Given this list of marker genes Spesp1, Pabir2, Pou2af2 (NCBI Gene Id 69809), Magi3, Or10ad1c, Fryl, Nrk, Ugt8a, Zmat2, Med1, Aqp6, Spock1, Plxnb3, Bcl11a, Stc2, Galnt7, Lman1, Atg14, Nsd1, Strbp, Csnk1d, Erfe, Tmtc4, Sh3rf1, Amph, Lrrn4cl, Casp2, Zfp24, Cacnb2, Fndc4, Rbm24, Evc, Glul, Chmp1b2, Mbd2, Rtn3, Cog5, Astn1, Usp3, Tpm1, Tshz1, Bend6, Ube2d3, Tox3, Foxf1, Hmcn1, Scn8a, Adgrd1, Abhd17b, 2410004B18Rik, Rmnd5b, Slc12a6, Armcx6, Trappc8, Plk2, Fam184a, Btaf1, Rpf1, Kcnd2, Babam1, Nfasc, Myo1e, Fbln2, Snap91, Atf7ip, Stac2, Rimbp2, Pigm, Nek6, Ppp4r2, Pcdhb10, Hycc2, Isca2, Cdh20, Nubp1, Mycbp2, Mylk, Nme7, Fry, Nfx1, Plxnc1, Epb41l3, Atp6v1c1, Ilk, Saxo2, Lztfl1, Bmal2, Phf20l1, Rab11fip1, Fbn1, Dpysl2, Mtcl2, Ube2i, Rarb, Hip1, Tacc1, Trdmt1 (tRNA aspartic acid methyltransferase 1), Prpf38b, Serpina3f, Col25a1, Zdhhc3, F11, here is a description of the gene set: from publication Chen Y, Wang X (PMID 31504780) species: Mus musculus Mouse Gene Set: MIR_216A_3P Genes predicted to be targets of miRBase v22 microRNA mmu_miR_216a_3p in miRDB v6.0 with MirTarget v4 prediction scores > 80 (high confidence targets).